The following is a description of a gene set: studied in species Homo sapiens Human Gene Set: GOBP_REGULATION_OF_RECEPTOR_SIGNALING_PATHWAY_VIA_STAT Any process that modulates the frequency, rate or extent of receptor signaling via STAT., and this is the list of marker genes: PPARG, CENPJ, HES5, PIGU, CRLF2, CISH, SH2B3, MIR125A, MIRLET7C, CAMK2A, MIR519A1, PTPRT, NEUROD1, DAB1, INPP5F, VHL (NCBI Gene Id 8056), CRLF3, MIR874, USP1, PIBF1, MIRLET7E, SOCS1, ADIPOR1, IFNAR2, CCL5 (NCBI Gene Id 8147), SOCS2, MIR9-1, NOTCH1, CLEC12B, JAK2 (NCBI Gene Id 3717), CSH1, GHR, PTPRC, CSF2RA, IL7R, EP300, IL6, IL9, GH2, ERCC6, CAV1, OCIAD2, PARP14, PTPN2, CSHL1, TGFB1, IL26 (NCBI Gene Id 55801), EGF (epidermal growth factor), TSLP, CALM1, PRL, PRLR, MGAT5, PTPRD, HES1, MIR146A, PTK2B, GH1, KIT, MST1, MIR149, HGS, IFNAR1, NF2, IFNG, MIR99A, ERBB4, OCIAD1, MST1L, CSH2, CYP1B1, F2, SOCS3, GADD45A, LIF, WDR48, RAC1, TYK2, JAK3, NLK, IFNL1, GGNBP2, BCL3, MIR340, IL10RA, LEP, ELP2, DOT1L, PTK6, MIR125B1, MIR221, IL5, IL10RB, F2R (NCBI Gene Id 2149), LEPROT, IL10, HMGA2, GBP7, EPHB2